The following is a description of a gene set: The controlled release of arachidonic acid from a cell or a tissue. studied in species Homo sapiens Human Gene Set: GOBP_ARACHIDONATE_SECRETION, and this is the list of marker genes: DRD2, DRD3, PLA2G2E, AVPR1B, PLA2G5, NTSR1, MIF (macrophage migration inhibitory factor), PLA2G2F, PLA2G12A (NCBI Gene Id 81579), PLA2G2D, PNPLA8, BDKRB2, DRD4, NMUR2, PLA2G2A, OC90, ANXA1, PLA2G1B, PLA2G12B, ACE, PLA2G4F, PLA2R1, PROCA1, PLA2G4A, NMB, PLA2G2C, PLA2G3, PLA2G10, SYK